Given this list of marker genes KCNQ1, CIB2, RDX, SLC12A2, KARS1, EPS8, KCNE1, NEUROG1, PMP22, PRPS1, FGF3, YARS1, MYO15A (NCBI Gene Id 51168), here is a description of the gene set: Profound hearing impairment species: Homo sapiens Human Gene Set: HP_PROFOUND_HEARING_IMPAIRMENT A profound (essentially complete) form of hearing impairment.